Given this list of marker genes ST3GAL2 (ST3 beta-galactoside alpha-2,3-sialyltransferase 2), KDSR, SMPD4, CERS1, PRKD1, CTSA, ST3GAL3 (NCBI Gene Id 6487), FUT2, UGT8, CERS4, UGCG, ASAH1, SGMS1, CERS3, ORMDL2, SMPD2, GLB1L2, GLA, ALDH3A2, M6PR, SPHK1, ST6GALNAC5, ARSJ, MFSD2B, PPM1L, SGMS2, SUMF1, PRKD3, GLB1L3 (galactosidase beta 1 like 3), NEU1, FUT1, PLPP2, A4GALT, CSNK1G2, ALDH3B1, GBA3, HEXA (hexosaminidase subunit alpha), ARSK, SPTLC2, DEGS1, CERS5, ARSA, HEXB, ST3GAL5, SPTSSA, SGPP1, ENPP7, DEGS2, B4GALT5, B4GALT6, ARSF, GALC, SGPP2, ORMDL1, CYB5B, B3GALT4, ARSG, CERK, B4GALNT1, SAMD8, PRKD2, ST8SIA5, PLPP1, ARSL, GBA2, ARSB, GBA1, ARSI, SPHK2, B3GNT5, SMPD3, NEU3, GAL3ST1, SPTLC1, CERS6, FA2H, SPNS2, ARSD, ORMDL3, ASAH2, VAPB, ACER3, OSBP, SMPD1, NEU4, SPTSSB, B3GALNT1, SPTLC3, SGPL1, ARSH, PSAP, SUMF2, VAPA, ALDH3B2, ACER2, ABCG2, GLB1, ACER1 (alkaline ceramidase 1), GM2A, NEU2, ST6GALNAC6, STS, GLB1L, CERS2, CERT1, ABCC1, PLPP3, here is a description of the gene set: species: Homo sapiens Sphingolipid metabolism Human Gene Set: REACTOME_SPHINGOLIPID_METABOLISM